Given this list of marker genes Ddx41 (DEAD box helicase 41), Tbk1 (NCBI Gene Id 80470), Stat6, Nlrp4c, Sting1, Dtx4, Irf3, here is a description of the gene set: species: Mus musculus Mouse Gene Set: REACTOME_STING_MEDIATED_INDUCTION_OF_HOST_IMMUNE_RESPONSES STING mediated induction of host immune responses